Given this list of marker genes RHAG, SLC11A1, BTBD9, MYO5B, ADGRF5, LIPA, NKIRAS2 (NCBI Gene Id 55590), TFR2, HMOX1, PRKACA, ABCA3, FBXL5, AKAP11, VEGFA, HFE, NAGLU, NEO1, SOD2 (superoxide dismutase 2), PICALM, B2M, BMP6, RCN3, CYP4A11, HEPH, AVP, INPP5K, AQP3, IREB2, KDR, SLC40A1, HAMP, EXT2, PRKACG, FECH, SCNN1A, ATP6V1B1, PRKACB, UMOD, CFTR, EXT1, OAS1, SCNN1G, EIF2AK1, TFRC, NKIRAS1, ITGB6, MBL2, TF, AQP6, HJV, CYP4F2, AQP2, LPCAT1, SFTPD, CTSH, AQP4, CYP4F12, AKR1B1, CYP11B2, MLLT6, TMPRSS6, CYBRD1, ABCA12 (NCBI Gene Id 3392), SLC11A2, HAS2, AQP1, EPAS1, TMEM63B, ADCY6, SCNN1B, TGFB1, WFS1, TMEM63A, NAPSA, TRPV4, EPB42, HYAL2, BPIFA1, GNAS, here is a description of the gene set: Human Gene Set: GOBP_MULTICELLULAR_ORGANISMAL_LEVEL_CHEMICAL_HOMEOSTASIS A homeostatic process involved in the maintenance of a steady state level of a chemical within extracellular body fluids, such as blood, xylem or phloem, of a multicellular organism. This is distinct from maintenance of cellular homeostasis, which occurs within a cell. species: Homo sapiens